The following is a description of a gene set: Genes down-regulated in CD4 T cells: untreated (0h) versus activated by anti-CD3 and anti-CD28 and then stimulated by TGFB1 and IL-12 (2h). Th1 and Th2 cells arise from a common precursor cell in response to triggering through the TCR and cytokine receptors for IL-12 or IL-4. This leads to activation of complex signaling pathways, which are not known in detail. Disturbances in the balance between type 1 and type 2 responses can lead to certain immune-mediated diseases. Thus, it is important to understand how Th1 and Th2 cells are generated. To clarify the mechanisms as to how IL-12 and IL-4 induce Th1 and Th2 differentiation and how TGF-beta can inhibit this process, we have used oligonucleotide arrays to examine the early polarization of Th1 and Th2 cells in the presence and absence of TGF-beta after 0, 2, 6 and 48 hours of polarization. from publication Lund R, Aittokallio T, Nevalainen O, Lahesmaa R (PMID 14607935) Human Gene Set: GSE2770_UNTREATED_VS_TGFB_AND_IL12_TREATED_ACT_CD4_TCELL_2H_DN species: Homo sapiens, and this is the list of marker genes: MX2, SMC2, COX17, METTL14, PCDHB3, MRPL9, TSPAN7, CYP27B1, SKA3, FAAH, ANAPC11, TRUB2, FBXO46, MYB, NDUFA5, COPS7A (NCBI Gene Id 50813), TDRD7 (NCBI Gene Id 23424), COL15A1, ZNF516, TPX2, XAF1, DYNC2H1, WNT5A, SLC5A2, NCK2, POLD1, LYPD3, HYKK, RNF114, TEX30, RRAD, SPMIP9, TBC1D22A, TOP2A, GNL2, OMG, CD96, UBE3B, USF2, TAFA4, CYP1B1, ANP32B, SMG9, PRC1, OARD1, PTHLH, PNPLA7, PHB2, MRPL28, FGD1, KRTCAP2, JMJD4, DOHH, THOP1, FARP1, NANS, AMIGO1, ADCY6, TRAFD1, ATP4B, NOBOX, ANKRD35, GOLGA3, CES3, CAPS2, AP1M2, KIF2C, WEE2, SYNE2, WDR1, GADD45B, CD1D, KRTAP21-1, TMPRSS2, RNF128, FGFRL1, TMEM37, MISP, MYH11, JPT1, ITGAL, CHFR, NHERF1, PAFAH1B2, DEPDC1 (NCBI Gene Id 55635), LY6G6C, SAC3D1, C4orf46, BIRC5 (NCBI Gene Id 332), CXCL10, SPMIP5, BAIAP3 (BAI1 associated protein 3), ALOX12, STPG4, ALDH1A3, CEP131, BRCA1, LRRC42, MXD1, TFEC, TNFRSF4, GREB1L, VWC2L, RDM1, CCNB2, CXCL14, BRK1, CDKN2C, CEP126, SLC6A19 (NCBI Gene Id 8062), COCH (NCBI Gene Id 23718), THYN1, PDZK1IP1 (PDZK1 interacting protein 1), DUSP10, CDC42BPB, TUBGCP3, SSTR4, CD93 (NCBI Gene Id 54591), ALDH18A1, ATP1B1, EMC1, BNIPL, PDLIM2, BRD8, KRT78, CDC123, GIMAP1, CYB561A3, TH, NSMCE3, CHST9, DCAF5, MIR1915HG, TMEM205, RER1, GPD2, ATG2A, IRF9, TUBA1B (NCBI Gene Id 88851), RTL8B (retrotransposon Gag like 8B), CDCA2, SPATA4, DDB1, DTNB, MAST2, IRF7, RAD54L, AHSP, CYSLTR2, TRIM28, HDGF, COL4A1, FBXL19, FTMT, APLF, TMEM127, FABP1, SDC4, LRFN4 (NCBI Gene Id 78999), PBK, SIK1, NOL6, WDHD1, NUSAP1, BMAL2, MRPL45, SLC44A2, JCHAIN, RCC2, ACO1, NPHP4, DNAJC3, ANKRD37, GNAT2, PAK4, TMPO, FHL3, ATP5MK, FZD10, SDC3, COL13A1, STK39, MOB1B, APRT, PDE6A, PRKAR2A, MAL, SPRY1, PEDS1, ADPGK, CDH1, PAFAH1B1, KCTD2, ZNF691, TFAP2C, PLCL1, HIC2, LUZP1, CAMK1G